The following is a description of a gene set: Human Gene Set: GOCC_BETA_CATENIN_TCF_COMPLEX studied in species Homo sapiens A protein complex that contains beta-catenin and a member of the T-cell factor (TCF)/lymphoid enhancer binding factor (LEF) family of transcription factors., and this is the list of marker genes: LEF1, TLE4 (TLE family member 4, transcriptional corepressor), TLE1, BCL9L, CTNNB1, TCF7, TCF7L2, PYGO2, TLE3, TCF4, BCL9, TCF7L1, LDB1